The following is a description of a gene set: species: Homo sapiens Junctional ectopic tachycardia (JET) is a unique type of supraventricular arrhythmia defined by narrow QRS complex and atrioventricular (AV) dissociation or retrograde atrial conduction in a 1:1 pattern. Junctional ectopic tachycardia Human Gene Set: HP_JUNCTIONAL_ECTOPIC_TACHYCARDIA, and this is the list of marker genes: CITED2, HCCS, MT-CYB, COX7B, NDUFB11